Given this list of marker genes TRA2A, FBXO34-AS1, SUDS3, H2BC11, G3BP2, C2CD2L, SNORD26, SARS2, RPL18A, TFPT, TENT4B, MRPS35, CHIC2, AKAP7, MDC1, PHPT1, RPL32, ANAPC10, FASN, MASTL, NME1-NME2, PMPCB, GABPA, LRRC40 (NCBI Gene Id 55631), C1orf53, PLXDC1 (NCBI Gene Id 57125), STAT1, SRPRB, YLPM1, PSME3, GOSR1, RANGAP1, CNOT6L, SPTLC1, ZNF551, TCTN3, CTDP1, C17orf100, ZNF239, LZTR1 (NCBI Gene Id 8216), SNORD54, PPIH, ADGRB3, SLC35F2, DEPDC1, CANX, MTIF2, POLN, UBIAD1, UBE2I (NCBI Gene Id 7329), RNU5E-6P, MST1P2, COX17, CDK5, SMARCA2, HSPA9, POLA2 (DNA polymerase alpha 2, accessory subunit), GATD1, UFC1, RINT1, RTF1, C9orf72, USP42, TP53, CACUL1 (NCBI Gene Id 143384), KIF15, NEUROD4, HNRNPH3, POFUT1, STAG3L5P, PPFIA3, SRCAP, FBXO34, ADD1, H3C10, PA2G4, MRPL20, ZNF3, SLC35B2, DNAJB1, ARL4A, UCHL5, RPL22, NAPEPLD, GADD45GIP1, NRL, EEF1AKMT3, TRIM52-AS1, PUS7 (NCBI Gene Id 54517), ZNF574, HLF, SUV39H2, MRPL4, ENKUR, HINT3, EPRS1, TIMM22, DCAF11 (NCBI Gene Id 80344), KRCC1, SNHG6, RSPH3, DUS3L, HOOK2, TRIM59, NFAT5, WDR87, SNAPC5, ARF6, ACAD9, ZNF736, NFIB, RRP12, PDCD6IP, FAM210A, TATDN3, WNT10A, DDX55, MALAT1, RBM12B-DT, NUF2, UBE2S, RPL10A, CCNE1, PPM1G, NEAT1, YME1L1, MRPS18B, ZNF587B, SRD5A1 (steroid 5 alpha-reductase 1), MEF2D, EIF2S2, YDJC, WDFY2, TAFAZZIN, TRAK2, IK, RHOQ (ras homolog family member Q), GABPB1-AS1, SFPQ, C6orf62, CHCHD10, COPS2, SNORD45C, PFAS, NDUFAF4P1, H3-3B, RIOK1, LINC01932, IFT172, NOSIP, JKAMP, RPL13, RPLP2, LTV1, AEN, RBM17, USP54 (NCBI Gene Id 159195), METTL25, MRPL53, PCBP1-AS1, EZH1, NIFK, HAUS3, XIST, RSL1D1, USP36, CFL1, SUPT5H (NCBI Gene Id 6829), RPL19, PRMT5, SPOCD1, PIGU, EMC7, PEMT, ARSK, RPL10, H4C2, UBXN6, ILF2, LINC01126, PCF11, HSD11B1L, DCAF4, PMS2, GRB2, NDUFA2, KDM2A (NCBI Gene Id 22992), NXF1, ENSG00000235978, JTB-DT, APRT, N4BP2L1, GALC, CEBPB-AS1, HDGF, SIPA1L3, MINDY1, B4GAT1-DT, H2BC12, HSP90AB1, THUMPD2 (THUMP domain containing 2), ODC1, ARHGDIA, DCXR-DT, EEF2K, EHD1, UHRF2, MIR4512, ERCC1, PRRG2, H2AC12, PIGL, FBXW5, NELFCD, SNRPB, EEF1B2, MIRLET7I (microRNA let-7i), SNHG5, TTC14, MRPL34, RCCD1, AP1G1, VPS9D1, POLE4, DMAP1, MRPS35-DT, AMPD2, HNRNPF, RSL1D1-DT, BRWD1, LIM2-AS1, ZNF131, H2BC10, SF3B4, RO60, SNORD27, MT-TG, C1orf52, BTF3L4, MTHFD2, RAD51D, TMED4, PCBP2, BRI3 (NCBI Gene Id 25798), ATP6V1E2, UBE2D3, MAST4, FNTB, LRRC58, HK2-DT, NDUFS1, MIR1538, SPAG7, TIMM8B, SCRT1, VPS9D1-AS1, SLC35E3, FNBP4, ING3, SNRPF-DT, PPA2, UBXN2A, MSL2, CDK6, AGBL5-AS1, CCNT1, MIR3678, BCAR3, PPDPF, SCAF1, NXT1, ZGPAT (zinc finger CCCH-type and G-patch domain containing), CCT2, RNF7, TM9SF1, ZNF460, NELFA, LARP1 (La ribonucleoprotein 1, translational regulator), TRIM52, GPR137, BAGE2, ALG13, GNL3L, CHTOP, TIMM10, PTBP1, ATAD2B, ASPSCR1, PLEKHG2, H4C6, ATXN2L, TTC14-DT, TBL3, TRAPPC11, HK2, RNF139-DT, DDX42, ZNF207, TPRA1, MIR3143 (NCBI Gene Id 100422934), ARFRP1, H3C1, FBXL9P, FRG1-DT, METTL25B, LRRC8B, HMGN4 (high mobility group nucleosomal binding domain 4), N6AMT1, VPS72, MTND5P11, CDKL3, ATG5, HERPUD1 (NCBI Gene Id 9709), MAST4-AS1, H2BC7, PPIA, YARS1, USP4, RCCD1-AS1, TAF12, SNORA7A, PRR3, RALGAPA1, HLA-B, SIL1, PDS5B, SPTBN1, RPL5 (NCBI Gene Id 90045), MRPS12, MFSD3, COPB2-DT, MRFAP1, LRP3, KMT2E, CCNB1, COX16, PHF7, C1orf43, CCDC59, BRD2, CERS6, RMI1, GABPB1, POLD2, CAMKMT, SNRPE, TRAM1, SEC13, ODC1-DT, SNHG12, SLC3A2, NSUN2, TARS1, TBL1X, PHF12, MCM3AP-AS1, ARID4A, SOD1, POLR2D, NBR1, RNF123, IQANK1, FLJ46284, EIF3G, SDE2, HIGD2A, FRG1, SNORD68, UBC, SERTAD3, DCXR, GLO1, METTL1, LIN54, CCNL1, YBX3, RPS6, AIMP2, SARAF, BRCA1, SLC9B2, GATC, LIMS1, HS2ST1, DIDO1, PRDX1, ATP5F1D, ZKSCAN2, UQCC4, H2BC15, TAGLN2, PUS1-AS1, NME1, LACTB2-AS1 (LACTB2 antisense RNA 1), IL5RA, MDN1, MCM2, POLE3, IDH3B, A1BG-AS1, XPOT, YWHAE, ENSG00000246308, GUF1, MAP2K7, TNIP2, PNPLA8, RGS5, COX20, MST1, YTHDF3-DT, MORF4L2, DPAGT1, CYB5R4, DDX31, TXNL4A, MIR22HG, JUNB, ZNF202, RETREG1, DDX19A-DT, PARP1, PLK1, ZNF692-DT, PRSS21, PNO1, RAB18, HMGB1 (NCBI Gene Id 3146), ORMDL3, RPL36, B4GAT1, BTBD19, PAXBP1 (PAX3 and PAX7 binding protein 1), PPP4R3B, EZH2 (NCBI Gene Id 392834), MORF4L2-AS1, EID2B, RPL37A, CENPT, HLA-E, HCG14 (NCBI Gene Id 414760), POLD3, RNU7-27P, TOP1, RSRC2, NOLC1, UMPS, CROCCP2, CDK6-AS1, GTF3C4 (general transcription factor IIIC subunit 4), MED20, PIGK, NFKB1, MIR4664, KNL1 (kinetochore scaffold 1), C9orf43, GTPBP3, DENR, TFG, H2AC10P, SLC38A1, SIKE1, DBP, CDC42SE1, USO1, BTG1, TTC33, RBM33, MIRLET7IHG, GTPBP4, ZNF441, PABPC1, RPSA, EIF2D, ZNF680, RPL27, TXN, MAGOHB, SNORA14B, DDX18, ZNF701 (zinc finger protein 701), PIDD1, RPS27L, MATR3, HEXIM2, RNVU1-15, PPP1R10, SRBD1, HDLBP, BTNL12P, PRMT2, GNL1, TRMT2A, LSM14A, RPL34, PRMT1, MRFAP1L1, RNF145, MRM1, SNHG7, GDI2, TACC3, ZC3HAV1, DHX15, AGBL5, NSL1, CAGE1, GLOD4, SNORD42B (NCBI Gene Id 26808), EIF2B4, TRNAU1AP, LINC02960, RNPS1, AURKB, RAN, NFE2L1, SELENOF, RBM28, CNOT4, PHF21A, MRPL30, NBN, UQCRH, ZNF839, KPNB1, NDUFS7, C17orf75, PCBP1, JTB, SNX5, SURF6, DGCR2, HMGA1, KIF23-AS1, TRIM33, SNHG1, RPS20, DHRS13, RNMT, MBD3L1, SNF8, TBC1D8, ATP5PF, CLTC, TMEM208, MAP3K14, CTNNBL1, TMEM104, WDR43, SHCBP1, TAF4B, BAP1, CSTF3-DT, TOMM5, LAMP1, BOLA1, ITFG2-AS1, ZNF879, MTND1P11, ASNS, H1-4, PHF14, THOC1, THBS3, SDHD, EIF2S3, QSER1, CHFR, VCPIP1, ZNF444, ULBP1, PPAN, KLF6, DHX9, ZFX, PNPT1, L3HYPDH, MMP11, TRIM59-IFT80, CHD2, RNF139, HEXIM2-AS1, C8orf33, PELP1-DT, PNRC2, ZNF442, G6PC3 (NCBI Gene Id 92579), ZBTB4, RPF2, PRMT5-DT (NCBI Gene Id 101926933), IFRD2, FMC1-LUC7L2, YTHDF3, RPL34-DT, HLA-DMA (NCBI Gene Id 3108), ENSG00000232995, PPAN-P2RY11, ARHGDIB, RBM39, RPL23A, GEMIN7, LDHB, AP3M2 (adaptor related protein complex 3 subunit mu 2), DARS1-AS1, CEBPG, TRMT61B, SERTAD3-AS1, ZNF785, TMA16, NUP153, F12, GTF2B, GALK2 (NCBI Gene Id 2585), ZFX-AS1, IDH3B-DT, TSN, RPL37A-DT, MAPK8IP2, PPRC1, SLC25A6, MAPKBP1, HSPA2, TMEM268, IMMP2L, MXD3, TNFSF8, ANP32B, PRDM15 (NCBI Gene Id 90172), PLD6, H2BC5, EPC1-AS2, ATAD2, GATD1-DT, DESI2, MIR4519, ARPC5L, PSMC4, TMEM129, C1orf122, RN7SL1, HNRNPA2B1, MIR762HG, NAT9, CSGALNACT2, CSTF3 (cleavage stimulation factor subunit 3), SOD1-DT, PHF11, TP53BP2, CDK1, CARS1, RAE1, P2RX5, PIPOX, TRIAP1, RPS15, KICS2, RANBP2 (RAN binding protein 2), PRUNE1, XPO1, EIF4G2, USP20, HAX1, TAF12-DT, LINC02901, MIR4521, C22orf46P (chromosome 22 open reading frame 46, pseudogene), SNORD25, NPW, MITD1, H4C3, SNRPF, SART1, PRCC, TTC12-DT, LYRM7, BBS1, CASP8, LIPT2-AS1 (NCBI Gene Id 374408), MIPEPP3, ACACA, MARK4, RAD23B, SLBP, BMERB1 (bMERB domain containing 1), NACA, PGBD4, MIR3677HG (NCBI Gene Id 106660606), UBFD1, HSPH1, UBAP2L, MIR3913-1, PITPNA, RAD9B, TRNT1, RGL4, TANK-AS1, EVI2A, EARS2, TXNDC12, PSMA3-AS1, SAR1B, MRPL11, SFT2D2, KIF23, BANF1, FANCD2, EIF1AD, NOP16, RIF1, LAMTOR5, DDX56, CCDC47, CCT8, CORO1A, MICOS13 (mitochondrial contact site and cristae organizing system subunit 13), EIF3E, EPCIP-AS1, ELOB (NCBI Gene Id 91153), PYCR1, PRPF31, IREB2, MTF2, NOP58, RPS14, GIT1, MTPAP, RASSF1, EID2, NCOA5, SRSF11, SMIM26, CLK1, PES1, RABGGTB, RN7SKP114, POP4, UBE2D2, ERICH1, H2AC7, EPC1-AS1, LRRC14, USE1, POLG-DT, SEPTIN2, MIR6855, PPAT, WDR81, WDR74, NUP153-AS1, SLC2A9, NDUFV3, KLHL28, LAMTOR5-AS1, MFGE8, SLC16A1-AS1, CSGALNACT2-DT, LSS, BYSL, RBM12B (RNA binding motif protein 12B), THRAP3, MIR663AHG (MIR663A host gene), POLR2A, ABCE1, FPGS, GPN3, KIAA1143, COPB2, LRRC41, CPSF7, TMEM185B, BTG1-DT, HSPA2-AS1, WDR6, SPATA13, CCDC191, DIP2A, BCAT1, DIAPH1, RABGGTA, RPS29, SRSF3, VPS29, BECN1, TMEM39A, DDX19A, HCFC1R1, SF1, C9orf78, ADNP, NCAPD3, COX10-DT, MED15, MGME1, BIRC5, STK17B, UBE2T, RASSF1-AS1, HMGB3P22, ZC3H15, SENP2, COX10, CERNA3, GABPB2, MTX1, C6orf89, KNTC1, TOGARAM1, SNU13, TSR1, H2BC21 (NCBI Gene Id 8349), MRPS30, H4C5, C14orf178, PFKP, MRPS30-DT, TANK, PRAF2, UBE4A, GID8, RANBP1, ZNF589, DYNC2I1, CIDECP1, MT-ND3, RWDD4, POLG, TARS1-DT, TTC12, PREPL, SACM1L, IARS1, S100PBP, STRADB (STE20 related adaptor beta), FAM86KP (family with sequence similarity 86 member K, pseudogene), POLR2E, GIT2, EEF1A1, MED31, UBE2D3-AS1, MIR5188, ZNF37A, TGIF1, CASC3, ZNF558, CAD, VEGFA, DTD1, VTA1, H4C1, PLAGL2, SKIC3, LGALS8, MRPS15, PPP2R5C, SLC19A1, DNAAF10, SDHAF2, H2AC15, CALM1, PPP2R3B, DPH1, RAD23A, BMS1 (BMS1 ribosome biogenesis factor), TOMM40, AP2B1, ZFP36L2, CLUH, SLC4A2, MRPL3, A1BG, RBM33-DT, QTRT2, DPP9, EIF1 (eukaryotic translation initiation factor 1), PARVB, ZNF121, RSL24D1, H2AC11, CREBZF, METTL8, CBX3 (chromobox 3), DDX1, ATP5F1A, PWP1, LY9, AP2A2, SMARCC1, MTHFS, VPS26B, SNAI1, STAG3L5P-PVRIG2P-PILRB, YJU2, KLF16, COMTD1, SPRYD4, BDP1, RPS24, C8G, ISG20L2, RPS23, PELP1, PPP4R3B-DT, CNN2, PUS1, PGAM1, ZNF692, FMC1, SELENOH, SNORA16A, LIMD1-AS1, MRM3, THOC1-DT, MCMBP, H2AC20, GNB2 (NCBI Gene Id 96628), KANSL2, LIPT2, ZNF598, MAP4, DCAF17, MT-CO3, ING5, DNPH1, SNX17, NLE1, UBAP2, here is a description of the gene set: from publication Yevshin I, Sharipov R, Kolmykov S, Kondrakhin Y, Kolpakov F (PMID 30445619) Human Gene Set: KAT5_TARGET_GENES Genes containing one or more binding sites for (KAT5) in their promoter regions (TSS -1000,+100 bp) as identified by GTRD version 20.06 ChIP-seq harmonization. studied in species Homo sapiens